The following is a description of a gene set: species: Homo sapiens Human Gene Set: SIX1_TARGET_GENES from publication Yevshin I, Sharipov R, Kolmykov S, Kondrakhin Y, Kolpakov F (PMID 30445619) Genes containing one or more binding sites for (SIX1) in their promoter regions (TSS -1000,+100 bp) as identified by GTRD version 20.06 ChIP-seq harmonization., and this is the list of marker genes: CAMTA1, ITPR1, TNFAIP8L1, LNCTSI, ICMT, DIAPH1, DNAJC11, PCBP3, GPER1, OXGR1, ELF3, CRIP2, ART5, ARL14, RNU5E-9P, RAB6A, YTHDF2, LARP1, GPR151, CLN8, EZH2, MAPK8IP1, TMEM132A, AFG2B, MEOX2, CALM1, COPZ1, RAPGEF3, SREBF1, GBX1, LINC01765, CASTOR3P, ANKRD6, FRMD4B, NRP1, TPT1-AS1, SPATA20, PRKCE, IFITM3, FTLP5, MC4R, ARHGAP15, MBD2, NOL4L, SEMA3B, PMEPA1, GLTP, KIF11, FANCG, GALNT16-AS1, CXXC1, TENM2, ACVRL1, C15orf61, ACVR1, PRKAG2, OAT, FBXW7, CTXND2, FGFR2, VPS37B, STUM, NDST2, COQ5, AFAP1, TBC1D22A, NKILA, SULT1C2, HTR3A, RND2, GATM, HLA-DMA, ALDH1A2, SIX4, MPC2, ALG1L1P, UHRF1, MYH9, TPT1, ZNF175, AP3B2, DCAF12, WDFY3, ANKRD28, KRT18P12, LINC01645 (long intergenic non-protein coding RNA 1645), CIBAR1, ST8SIA4, MEOX1, FAM240C, MRPL20-AS1, ETFA, GABRB3, IQCH-AS1, LAMP1, EPHX1, ENSG00000282012, USP12, SMAD6, SASH1, ACVR2A, SIX2, PFN2, B3GALT5-AS1, SLC44A3 (NCBI Gene Id 126969), PPP3CB-AS1, CHD8, RBMS1 (RNA binding motif single stranded interacting protein 1), COX7A2L, GPC1, PPP1R21, FKBP14-AS1, IGFBP5, MGC16275, CNTNAP2, STAP2 (signal transducing adaptor family member 2), FNBP4, RNA5SP384, REL-DT, ENSG00000273162, SIX1, SLC39A3, EPB41L5, GPC1-AS1, TRAPPC2L, EOLA2, LINC00923, C1orf54, YPEL3-DT, ARFGAP1, USP2, CNIH3-AS2, ADD2, IFITM1, ETV6, LRRN4, LEF1, ZNF496, GTPBP2 (NCBI Gene Id 54676), HDAC1, ACACB, FKBP2, ABCA4, DLG5, C4orf51, TCIM, LINC01571, TSHZ1, CPZ, SERINC5, REL, XPO6, LINC01915, C2CD4A, GRAMD1B, LIMS2, STAU1, TTYH2, NKAIN4, BLOC1S5, GZF1, KAZALD1, TPM1 (tropomyosin 1), IFITM2, MIR361, LINC02303, REST, LARGE1, SHROOM3, PRKAR1A, SEPTIN9, CCNL2, SPECC1P1, FRAS1, MPDZ, H2BC16P, B4GALNT3, MEGF8, ENSG00000235480, SCARB1, C1QTNF7, ZNF331, PXDNL, CDKAL1, DDI2, UST (NCBI Gene Id 10090), HOXA-AS3, CNKSR3, BACH2, EXPH5, GPR146, FIBIN, BBS4, PSMA6P4, DDX4, CHAF1A, ZC2HC1A, COL2A1, SMC4, PLXNB1, UNC119, MIAT, PDYN-AS1, TLDC2, RPL21P92, B3GALT5, TTBK2, TMC2, PCCA-DT, DOT1L, FRMD6, COL24A1, LRRC30, SLC48A1, ARMC1, SRBD1, SEMA6D, ZMIZ1, FAM107B, KIAA0319L, ANO2, MIR3713, CHRNA9, SCAANT1, FSD2, CABLES1, FAM81A, COL13A1, GPAM, TMEM200C, CASC18, BMPR1A, ICMT-DT, RNU6-920P, NUP50-DT, ATL2, NADK2, PARP1, CADM1, MIR1273C, PTPRJ, MPND, PIGR, PLEKHD1, HDAC11, IGFL4, HES6, ETV4, LPIN1, ELSPBP1, RAB11FIP4, ELF3-AS1, FKBP1A, CDH24, SLC22A4, CORO2A, LINC01775, LEF1-AS1, CENPT, NCDN, HPGD, CILP, TP53, BRD2, ARRB1, PRSS23-AS1, ADPRHL1, DOCK4, NFRKB, TTC24, ALDH3A1, SSC4D, PDIA5, ADGRA2, SMG1P3, COL1A1, GNAL, NFE2, RGS17, NSA2P4, IGF1R, PPP2R3B, HSD17B14, ISCA2P1, PDE11A, EIF4H, C5AR1, GLI3, GALK2, RDX, ANK3, BLOC1S5-TXNDC5, ADCY5, NXN, POU6F2-AS1, EPB41L3, LRRC27, LINC01708, SINHCAF, CNIH3, PSKH1, SV2C, ENSG00000258716, MRPS9-AS1, FARSB, LSM12, PSMB4, C11orf52, P4HTM, GALNS, IQSEC3-AS2, UCHL1, CEP350, ZNF738, MAPK10, RPL38 (ribosomal protein L38), POLR3C, H2AC16, ARHGAP24, AP2A2 (adaptor related protein complex 2 subunit alpha 2), DZIP1L, DAB2IP, EOLA2-DT (EOLA2 divergent transcript), ESPN, KRT35 (keratin 35), CARF, ATN1, RBM17, TPRG1-AS1, SYTL2, ENSG00000260520, LRRC17, HS1BP3, LINC00903, SLIT3-AS1, SART3, LIFR, SLC7A5P2, WT1, TMEM127, YPEL3 (NCBI Gene Id 83719), SEMA3C, STRADA, DEF6, DPP10, GLI4, ZNF736, AKAP6, LLGL2, NAV2, WDR12, ARRDC4, ALG10B, PTBP1, TMEM274P, COL9A2, YBX3, DM1-AS, HADHA, NUP50, TMEM100, CARMIL1, PRELID3A, LINC00687, CCDC8, SEMA3B-AS1, AGPAT4, WRAP53, ANO3, TFDP2, PPP3CB (protein phosphatase 3 catalytic subunit beta), SEC14L1, FAM13A, METTL2A, THAP11, PCCA, TENM3, ARHGEF7-IT1, SLC11A2, ATP11A, EFR3B